The following is a description of a gene set: Mouse Gene Set: MEISSNER_NPC_HCP_WITH_H3K4ME2 from publication Meissner A, Mikkelsen TS, Gu H, Wernig M, Hanna J, Sivachenko A, Zhang X, Bernstein BE, Nusbaum C, Jaffe DB, Gnirke A, Jaenisch R, Lander ES (PMID 18600261) studied in species Mus musculus Genes with high-CpG-density promoters (HCP) bearing histone H3 dimethylation mark at K4 (H3K4me2) in neural precursor cells (NPC). DNA methylation is essential for normal development and has been implicated in many pathologies including cancer. Our knowledge about the genome-wide distribution of DNA methylation, how it changes during cellular differentiation and how it relates to histone methylation and other chromatin modifications in mammals remains limited. Here we report the generation and analysis of genome-scale DNA methylation profiles at nucleotide resolution in mammalian cells. Using high-throughput reduced representation bisulphite sequencing and single-molecule-based sequencing, we generated DNA methylation maps covering most CpG islands, and a representative sampling of conserved non-coding elements, transposons and other genomic features, for mouse embryonic stem cells, embryonic-stem-cell-derived and primary neural cells, and eight other primary tissues. Several key findings emerge from the data. First, DNA methylation patterns are better correlated with histone methylation patterns than with the underlying genome sequence context. Second, methylation of CpGs are dynamic epigenetic marks that undergo extensive changes during cellular differentiation, particularly in regulatory regions outside of core promoters. Third, analysis of embryonic-stem-cell-derived and primary cells reveals that 'weak' CpG islands associated with a specific set of developmentally regulated genes undergo aberrant hypermethylation during extended proliferation in vitro, in a pattern reminiscent of that reported in some primary tumours. More generally, the results establish reduced representation bisulphite sequencing as a powerful technology for epigenetic profiling of cell populations relevant to developmental biology, cancer and regenerative medicine., and this is the list of marker genes: Lgr6, Col25a1, Fgf12, Gnal, Fhdc1, Cplx2, N4bp3, Grik2, Rapgefl1, Lsr, Hmga1, Slc16a12, Agtrap, Vipr2, Hsd11b2, Kcnq4, Pgap2, Lhx9, Rimkla, Creg2, Rtn1, Dlk1, Irf8, Trim65, Slc2a4, Ace, Rab43, Slc1a6, Grhl3, Smpdl3a, Boll, Tpm1, Wnk4 (WNK lysine deficient protein kinase 4), Pthlh, Slc16a9, Pacsin1, Ak8, Nsd1, Itpka, Slitrk4, Rbp4, Lrrk1, Nkx3-1, Dll3, Gpr150, Adra1b, Avpr1a, Galr2, Bcorl1, Hic1 (NCBI Gene Id 15248), Zdhhc23, Casd1, Mlkl, Shcbp1l, Plppr4, Prrg4, Nrip3, Slc4a3, Doc2a, Cyp46a1, Gm266, Kcnb1, Sncb, Sypl2, B3galt4, Kcnj8, Spock1, Syt6, Adamtsl4, Rai1, Atp9a, Pdlim1, Prima1, Hhipl1, Dipk1b, Fbln2, Trpm3, D630003M21Rik, Nfe2l3, Dcaf12l1, Syngr3, Spmip4, Tmem62, Cys1, Lrrc3b, Has3, Ydjc, Neurl1a, Necab2, Trim14, Rasgrp1, Pde4dip, Prkg2, Twist2, Pitpnm3, Mfhas1, Ch25h, Shisa7, Efna2, Marchf11, Ccdc122, Ccnb2, Rhof, Ank1, Slc25a13 (NCBI Gene Id 50799), Snx32, Slc44a1, Marchf10, Hes3, Gda, Lrrc75a, Tc2n, Mlxipl, Ltk (NCBI Gene Id 17005), Tmem117, Tll2, Arhgap29, Copz2 (NCBI Gene Id 80532), Popdc3, Ltbp4 (latent transforming growth factor beta binding protein 4), Camsap3, Ptgr2, Slc35f3, Osbp2, Mxra7, Ror2 (NCBI Gene Id 26564), Brsk2, Sync, Nptx2, Nmi, Nherf2, Hps6, Mapk8ip1, Marchf9, She, Map7, Mpg, Slc27a3, Lhfpl4, Vdr, 1700067K01Rik, Kif16b, Adcy3, Lmtk2, Itgb3, Grik4, A830018L16Rik, Hapln4, Gpr153, Aqp5, Anxa2, Syt13, Brinp1, Aig1, Pcdhac1, Ntf5, C2cd4c, Ptpre, Zc3hav1, Mgat5b, Plagl1, Espn, Slc8a3, Tcea2, Marchf4, Samd10, Unc119, Edaradd, Plpp2, B3gnt5, Hfm1, Llgl2, Dnajc6, Tnfsf11, Cebpb (NCBI Gene Id 18031), Slit3, Chrnb2, Mfsd4b1, Sidt1, Insm1, Ptprb, Stard10, Pls1, Kcnk2, Tmem151b, Adamts18, Creb3l1, Mfsd4a, Itpr3, Cib2, Abr, Fgf18, Nfatc2, Lif, Rbfox1, Onecut2, Pkp2, Dpp6, Sox1ot, Bcl11a, Map7d2, Dnajc15, Srrm4, Kcnj10, Rab37, Col2a1, Gdf7, Snta1, Cnih2, Kctd15, Olfml2b, Raver2 (ribonucleoprotein, PTB-binding 2), Adam11, Chrna7, Atp1a3, Mbp (myelin basic protein), Rrad, Adra1d, Cbs, Rnf144b, Svop, Slco5a1, Aebp1, Mtus2, Plekha2, Lox (lysyl oxidase), Alx4, Gnaz, Nnat, Fmnl1, Dtx1, Comp, Agbl4, Rims1, Ly6e, Prdm8, Elavl2, Slc37a2, Ccdc3, Dnaja4, Ikzf1, Snx22, Trpv4, Gpr50, Ttc34, Abca2, Btbd6, Pced1b, Dleu7, Scn1b, Cyrib, Setd6 (NCBI Gene Id 66083), Chd5, Grin2d, Lrrc3, Nrg3 (neuregulin 3), Ramp2, Gpr101, Abcb4, Adap2, Ada, Il7, Fam83f, Slc37a1, Rspo4, Slc32a1, Cyb561, Cdkn1c, Il13ra1, 9130019P16Rik, Reep2, Zfp804a, Cpxm1, Fgf4, Acot12, Etl4, Il4ra, Ctsf, Cacna1g, Map4k2, Plppr5, Ache, Stk26, Hyi, Gsc, Fam20a (FAM20A, golgi associated secretory pathway pseudokinase), Arvcf, Gad2, 1190005I06Rik, Col23a1, Dusp15 (NCBI Gene Id 99102), Decr1, 2700062C07Rik, Tmem121b, Arhgdig, Kcne5, Sertad4, Hoxd8, Kcnk6, Col12a1, Batf3, Galnt12, Tagln2, Ccna1, Prrx2, Wtip, Adamts5, Dlx4, Col16a1, Pex7, Col9a3, Pik3ap1, Adam23, Ccdc17, Mtmr7, Npr2, Calb2, Clmp, Rcan2, Nexn, Myo5b, Nrk, Prickle2, Gata3, Smad9, Pde8a, Slc2a6, Cd248 (CD248 antigen, endosialin), Xk, Pear1, Slc27a2, Gpc3, Slc12a7, Mt2, Ablim3, Sbspon, Zim1, Pm20d2, Myo1c, Ebf2, Fbxl21, Htr1b, Arc, Nkd2, Ttc9b, Ybx2, Gdf10, Loxl2, Irx6 (NCBI Gene Id 64379), Ppp1r14a, Tcerg1l, Adamts19, Wdr31, Zmat4, Gulp1, Chgb, Cgas, Zfta, Emilin2, Smagp, Srsf12, Bmp3, Gas6, Dipk1c (divergent protein kinase domain 1C), Net1, Perp, Tm6sf1, Elovl2, Crlf1, Pgf, Ttc39a, Barx1, Card10, Dpysl4, Ucp2, Ankrd35, Cep170b, Lpar3, Sema4d (NCBI Gene Id 20354), Tsc22d3, Arhgap28, Bmp7, Dnm1, Radil, 1600014C10Rik, Olfm1, Epcam, Arhgef25, Acss1, Sox30, Il10rb, Hs3st3a1, Hps1, Cfap20dc (CFAP20 domain containing), Lmx1b, Ly75, Erfe, Nsun7, Tes, Epop, Npy, Spint2, Acbd4, Tcf7, Rac3 (NCBI Gene Id 170758), Plxdc1, Drd4, Tmem132d, Tmem238, Parp12, Nrtn, Dapk2, Trnau1ap, Vwa1, Fcho1, Sema4b, Nkx1-2, Kcnh4, Aatk, Tert, Alpl, Tlcd4, L3mbtl1, Wnt2, Rftn1, 1700019D03Rik, Rfx2, Uckl1, Grtp1, Dync1i1, Otud7a, Tcea3, Scube2, Ccdc116, Dysf, Usp2, Il17ra, Sema3f, Cpxm2, Gprin1 (NCBI Gene Id 26913), Aifm2, Lyzl4, Tnfaip8l3, Snai1, Glt1d1, Rtl6 (NCBI Gene Id 223732), Rasal1, Csrp1, Hrh1, Fa2h, Kcnf1, Patj, Lpgat1, Fgf2, S100a11, Pld2, Emp2, Col18a1, Foxa2, Epb41l3, Lgi2, Golga7b, Spock2, Tent5b, Mn1, Celf4, Nmb, Dusp18, Lrtm2, Diras2, Fam241b, Wnt2b, Htr6, Slc6a4, Bsn, Matk, Prr5 (proline rich 5 (renal)), Grk3, Ccdc184, Adrb2, Nkx6-2, Aldh1a3, Mfsd2a, Nxnl2, Rap1gap, H1f0, Nenf, Rcsd1, Flnc, Gipc3, Ankrd13d, Slc44a5, Fzd6, Mnd1, Cacna1b, Gp1bb (NCBI Gene Id 14724)